Given this list of marker genes ATP2A2, TMEM94, TAP1, ATP2A3, TAP2, here is a description of the gene set: species: Homo sapiens Human Gene Set: GOBP_CYTOSOL_TO_ENDOPLASMIC_RETICULUM_TRANSPORT The directed movement of substances from the cytosol to the endoplasmic reticulum of a cell.